The following is a description of a gene set: Reactome Pathway: Signaling by ERBB2 KD Mutants species: Homo sapiens Mutations in the kinase domain (KD) of ERBB2 result in constitutive activation of ERBB2 signaling, facilitate heterodimerization of ERBB2 with other EGFR family members and increase the signaling intensity, leading to cellular transformation.<br>Only a subset of potential heterodimerization partners has been tested for most ERBB2 KD mutant proteins, so our annotations here are correspondingly limited. ERBB2 L755S and ERBB2 V777L cancer variants were shown to heterodimerize with ERBB3 (HER3) at a higher rate than wild type ERBB2. Increased activity of ERBB2 L755S, ERBB2 L755P, ERBB2 V777L, ERBB2 D769H, ERBB2 D769Y, ERBB2 V842I, ERBB2 R896C and ERBB2 G778_P780dup in the presence of either EGFR or ERBB3 as a heterodimerization partner was also observed. The interplay of ERBB2 G778_P780dup, ERBB2 I767M and ERBB2 R896C with ERBB3 has not been tested. ERBB2 L869R mutant shows increased activity in the presence of ERBB3, which is further augmented in the presence of dimerization-facilitating ERBB3 E928G mutants. The interplay of ERBB2 L869R with EGFR has not been tested. Heterodimerization of ERBB2 KD mutants with ERBB4 has not been tested and ERBB4 is a candidate heterodimerization partner for these KD variants.<br>ERBB2 H878Y mutant has ten times higher kinase activity than the wild type ERBB2 (Hu, Wan et al. 2015; Hu, Hu et al. 2015), but its heterodimerization properties have not been studied and it is therefore annotated as a candidate.<br> Ligand requirements have not been studied in the context of heterodimerization of ERBB2 KD mutants, but it is assumed that ligands are required.<br> The signaling properties of ERBB2 L755M, ERBB2 L755W (COSMIC database: Forbes et al. 2017), ERBB2 V777E, ERBB2 V777M, ERBB2 D769N, ERBB2 V842E, ERBB2 R896H (Cancer Genome Atlas Research Network 2011), ERBB2 L869Q and ERBB2 H878R have not been experimentally tested, but they are predicted to be pathogenic (COSMIC database: Forbes et al. 2017) and they are annotated as candidates. ERBB2 T733I, ERBB2 T798I and ERBB2 T798M usually occur as secondary ERBB2 mutations and are responsible for treatment failure. On their own, ERBB2 T733I and ERBB2 T798I appear to be weakly transforming compared with the other ERBB2 KD mutants. As their signaling properties have been poorly studied, ERBB2 T733I, ERBB2 T798I and ERBB2 T798M are annotated as candidates.<br>The binding of ERBB2 KD mutants to ERBIN and the HSP90:CDC37 chaperone:co-chaperone complex has not been tested but is assumed to occur similarly to the wild type ERBB2.<br>Signaling by ERBB2 KD mutants has been organized into subpathways based on the current knowledge of biology of these mutants (heterodimerization, downstream signaling, drug interaction) and on the sequence similarity of their mutations. part of: Signaling by ERBB2 in Cancer, and this is the list of marker genes: NRG2, ERBB3, PIK3CA, SHC1, CDC37, NRG1, GRB2, NRAS, ERBB4, PLCG1, NRG3, EGFR, EREG, KRAS, ERBB2, HBEGF (NCBI Gene Id 1839, heparin binding EGF like growth factor), NRG4, GAB1, HSP90AA1 (heat shock protein 90 alpha family class A member 1), PIK3R1, EGF, BTC, SOS1, HRAS, ERBIN